Given this list of marker genes THBS4, HES1, ACVR1B, EEF2KMT, TOPORS, SRMS, SIRT5, SOCS4 (suppressor of cytokine signaling 4), CDK1, PTK2, CDK10, TNKS, ZMIZ1, PDK3, MAPK1, ZDHHC20, DPH1, RAP2C, BCL11A, GALNT3, DPH5, BLOC1S1, PLK1 (polo like kinase 1), PDCD10, S1PR2, NSD1, RNF212, MDM2, HINT1, ZDHHC14, PTK2B, CDK5R1, METTL21C, SIRT4, POGLUT1, SIRT2, EGFR, PIAS3, SLF2, PRMT1, NSMCE4A (NSE4 homolog A, SMC5-SMC6 complex component), NSMCE1, SENP2, PDF, IGF1R, FLT3, CTH, UHRF2, SENP5, HDAC4, KAT2B, MAPK3, SMG1, NNAT, IL21, SMC5, BRSK1 (NCBI Gene Id 84446), PTPN2, IVL, CNOT9, ZDHHC2, PRKX, ERRFI1, CLIP3, IRGM, CREBL2, USPL1, LCK, GNL3, AGBL2, HDAC9, FGFR3, BTK, ZDHHC7, CNOT7, MORC3, VKORC1, SENP7, IKBKB, MBOAT4, STK11, P3H4, RIPK2, FLT4, TTLL3, S100A8, LTK (NCBI Gene Id 4058), FOLH1B (NCBI Gene Id 95211), PLK2 (NCBI Gene Id 10769), PIBF1 (NCBI Gene Id 10464), FGR, RASD2, DDR1 (discoidin domain receptor tyrosine kinase 1), VCPKMT, LOX, HIPK2, SUMO4 (small ubiquitin like modifier 4), DESI1, ZGPAT, CFAP20, TNNI3K, HIPK3, PCK1, NOS2, FES, PRKCD (protein kinase C delta), WNK3, ABI3, TNFRSF18, KIT, FLT1, PDGFRB, GALNT11, NAT8B, SUMO3, TRIM27, GALNT1, TGFB1, GNL3L, CDKN2A, IL18, LIF, FOLH1, ESCO1, MKNK1, EGLN2, ERN1, ZDHHC21, UBE2I, LIPT2, PARP9, KIAA1586, IL15, TENM1, RASSF2, NMT2, NDUFAB1, EHMT2, MAGEA2, KAT2A, EEF1AKMT3, IL20, HHAT, CBX4, GOLGA7, HCK, MAP3K10, TXN, TOP1, FER, DPH3P1, TTLL7, PIKFYVE, UBA2, VEGFA, STK39, POGLUT2, ARHGEF2, TRIM6, NMT1, APOA1, CAMK2A, RANGAP1, NSMCE3, MYLK2, ABL2, SOCS5, EEF1AKMT1, DIP2A (disco interacting protein 2 homolog A), CLSPN, TNFSF18, STK4, GALNTL6, VIPAS39, SIRT3, TRPM4, SAE1, NTRK1, PFN2, NAA20, PRKCE, TSG101, ULK1, JAK3, NDUFAF7, ENPP2, KDR, JAK2, HDAC7, GALNT2, AURKA, ANGPT4, STOX1 (NCBI Gene Id 219736), NEDD9, HMG20A, CHMP6, MAPK8, PDGFB, SUMO1, SETD7, PLOD1, VPS25, DYRK1A, INPP5F (NCBI Gene Id 22876), RELA, SMC6, SLF1, ARNT, ADAM17, ZNF451 (NCBI Gene Id 80822), QPCT, IL31RA, EP300, ANGPT1, SMYD2, SPRY2, CNTF, ATPSCKMT (ATP synthase c subunit lysine N-methyltransferase), CTNNB1, TTLL10, ANTKMT, STX1A, PTPN1, GAPDH, PAQR3, RAF1, METTL18, AKT1, DPH6, GPRC5B, SRC, ABI1, PML, PRKDC, AGBL1 (AGBL carboxypeptidase 1), PIAS1, SIRT1 (NCBI Gene Id 23411), ZDHHC15, ABI2, IL12A, PRLR, ZMIZ2, EPHB2, PTPN6, SETD2, PLOD3, DIP2B (disco interacting protein 2 homolog B), CEP41, PARP14, ROCK1, BANK1, ARL2BP, PKD1, APOA2, TGFBR1, CEMIP, TOLLIP, ZDHHC18, DPH7, PPIL1, EFNA1, VPS33B, PTEN, OGFOD1, ZDHHC9, SYK, SFRP2, UNC119, NAT8, LMTK2, EPHA3, FYN, RWDD3, TRIM38, SETD3, P3H2, KMT5A, NFATC2IP, MAD2L2 (mitotic arrest deficient 2 like 2), EGR1, PRKCA, FGFR1, CASS4, KAT7, CD80, BLK, TRIM28, MGAT5B, BAG6, PARD3, FGFR2, ALK, P3H3, MARK2, DHPS, CSKMT, KAT5, CREBBP, DPH2, VEGFB, DOHH, ZDHHC3, CAPN3, EGF, ZFYVE28 (zinc finger FYVE-type containing 28), JMJD6, PRMT5, EFNA5, RANBP2, OSM, PIAS4, NLK, CHI3L1, IL6, RAP2B, PTK6, TNK2, RAB6A, FGFR4, ERBB2, IFIH1, RIPK1, IL11, NAA60, ZDHHC11, SUMO1P1, POGLUT3, ARAF, GALNT6, IFNG, NRG1, CHEK1, MUL1, AGBL5, MAGEA2B (MAGE family member A2B), ZBED1, GALNT13, LACRT, DNAJC24, SUMO2, EYA1, CSNK2B, DPH3, SAMSN1, GPRC5A, CSPG4, HRG, GADD45A, UHMK1, EOGT, SNX6, NSMCE2, TTLL8, TBK1, BRAF (NCBI Gene Id 673), SETD6, PRKD1, ZDHHC19, LOXL3, EID3, PRMT8, NLRP2B, TTLL4, IFNL4, MVP, PIAS2, LILRA5, GALNT16, SRPK2, IFNL1, PPIA, GSK3B, CDK2, ERBB4, KLF15, LYN, S100A9, SFRP1, ATM, SRCIN1, CADM4, PDGFRA, EPHA7, PLOD2, TTLL6, TTBK1, TTBK2, FGF7, PRKACA, UBE2K, ATAT1, NEK6, VKORC1L1, EFEMP1, DDR2, NAA80, MAP2K2, AGBL4, PRMT7, ABL1, PIN1, NT5DC2, NTMT1, AGBL3, SENP3, ZDHHC8, EHMT1, FGF10, ITGB2, CSF1R, EPHA4, QPCTL, PRKD2, EEF1AKMT2, LOXL2, MAP4K1, PKDCC, DMTN, TPST2, PDCL3, ATF2, SENP1, P4HB, SPHK1, EGR2, SENP6, PARK7, DOK7, RPS6KB1, ZDHHC12 (NCBI Gene Id 84885), CNKSR3, ERCC6, GALNT4, TTLL1, FSCB, CTF1 (NCBI Gene Id 1489), HMG20B, ZAP70, TLK2, AGTPBP1, here is a description of the gene set: Human Gene Set: GOBP_PEPTIDYL_AMINO_ACID_MODIFICATION The alteration of an amino acid residue in a peptide. species: Homo sapiens